Given this list of marker genes IL12RB1, STAT1 (signal transducer and activator of transcription 1), CARMIL2, CARD9, TRAF3IP2, AIRE, IL12A, ATR (NCBI Gene Id 57307), TNPO3, SDR9C7, NFKB2, MMEL1, DOCK8, POU2AF1, CLEC7A, PLCG2, TNFSF15 (NCBI Gene Id 9966), IL17RC, HPGD, SPIB, CYBC1, KRT1, IRF5, here is a description of the gene set: Human Gene Set: HP_ONYCHOMYCOSIS Onychomycosis studied in species Homo sapiens A fungal infection of the toenails or fingernails that tends to cause the nails to thicken, discolor, disfigure, and split.